The following is a description of a gene set: studied in species Homo sapiens Human Gene Set: GOBP_RECEPTOR_INTERNALIZATION A receptor-mediated endocytosis process that results in the movement of receptors from the plasma membrane to the inside of the cell. The process begins when cell surface receptors are monoubiquitinated following ligand-induced activation. Receptors are subsequently taken up into endocytic vesicles from where they are either targeted to the lysosome or vacuole for degradation or recycled back to the plasma membrane., and this is the list of marker genes: NRG1, CALCA, DTNBP1 (NCBI Gene Id 84062), ACHE, LRRTM2, RALB, WNT3A, EFNB2, RNF220, ENTREP1, CD63, AHI1, RAB5A, SNCA, ARAP1, SELE, USP6, NEDD4, SCRIB, PLCG2, AP3M1, CXCR1, ANKRD13D, CD9, VEGFA, ITGB3 (NCBI Gene Id 3690), SCYL2, CD36, UBQLN2, RIN3, SFRP4, MX1, CALY, LRP1, GSG1L, CD81, ADM, NCDN, LRPAP1, NUMB, APP, CLTC, ACKR3, ANGPT1, GRB2, GRK3, GRK2, AP2M1, PICK1, EGF, NTF3, CXCL8, CBLB, GREM1, MX2, GTF2H2, NECAB2, RSPO1, VAC14, WDR54, NEDD4L, DKK1, HPCA, DRD3, CALCRL, DNM3 (NCBI Gene Id 26052), EPS15, LILRB1, MDM2, FMR1, FCER1G, MKLN1, SDCBP, INSR, DRD4, EZR (ezrin), HAMP, SNX1, ANXA2, CXCR2 (NCBI Gene Id 3579), RAMP2, LMBRD1, RAB31, SYT17, LDLRAP1, MAGI2, ARRB2, USP46, CEACAM1, ITGB2, ARRB1, DRD2, GH1, ATXN2, AP2A2, ITGB1, PICALM, AP2S1, LPAR1, PLD2, PPP3R1, DNM2, ARC, RAMP1, ITCH, GRIA1, HIP1 (NCBI Gene Id 3092), ANKRD13A, SUSD4, HGS, CAV1, DLG4, ARR3, SYK, RAMP3, CAV3, SAG, MIR199A1, LILRB4, APLNR, DNM1, ATAD1, RABEP1, MTMR2, SH3GL2, GHR, APELA, TFRC, GRK4, ARF1, OPHN1, ANKRD13B, AP2B1, AP2A1, FLOT1, LRRTM1, TBC1D5, CNTN2, RALA, PCSK9, APLN, TAMALIN